The following is a description of a gene set: species: Homo sapiens Ectoderm differentiation Human Gene Set: WP_ECTODERM_DIFFERENTIATION, and this is the list of marker genes: SDCBP, HDAC10, ANKS1B, GLI3, GATA6, CTBP1, CDH8, JUP, LHX1, BCAS3, SPRY2, EDA, BAZ1A, NFATC1, CCL2, TRIM33, RRBP1 (NCBI Gene Id 6238), ELOVL4, ZBTB2, SNCA, ZFHX4, ASTN1, PI4KA, H2BC9, ARX, BOC, PLCXD3, ZBTB16, BCOR, MIR15B, PODXL, PAN2, PRKAG2, CDH6 (NCBI Gene Id 1004), KCNK10, ARHGEF9, MIR361, FOXL1, CELSR2, VAX2, SMURF1, NUMA1, JAKMIP1, SKIL, MKS1, SERPINB6, CDON, SIX6, KIFC3, DMD, GREB1, MZF1, PAX3, TSKU, SMAD4, TNFRSF11B, TFAP2A, TCF7L1, PPFIBP2, STX16, PLXNA2, PPARD, SHH, ELOVL2, TTC14, NLGN1, GLB1, C1GALT1, UBTF, CLVS1, TRPM2, MECP2, CAP2 (cyclase associated actin cytoskeleton regulatory protein 2), YJU2B, MYC, TBL1X, SOCS2, NARS2, WNT1, ARHGAP10, FZD8, KRT6A, CROCCP2, FHL2, NF2, ABCC4, HMGB2, FGFR2, ZNF219, PGM1, FZD5, RGMA, EDA2R, PDE7A, FZD4, TLE5, STC1, POU2F2, ROR2, BMP4, TCF3, LY6E (lymphocyte antigen 6 family member E), FYN, CTNNA2 (catenin alpha 2), FOXA2, GAS2L1, SOX2, CLDN11, BMPR1A, TSC22D1, ZBTB7B, HESX1, ARHGDIG, PTPN13, HDAC6, MIR34C, TFAP2C, NR2F2, ARHGAP15, PTPRB, MAFB, RIT1, PHF8, TOX3, AHI1, SGSM3, CTNND2, RHPN1, PIM1, PAX6 (NCBI Gene Id 5080), MYORG, CCDC88C, LDB2, OGT, SCHIP1, CTNNB1, ST8SIA4, NLK, GRAMD1B, WDR44, SORCS1, RAB8B